Given this list of marker genes Tmt1b, Tpmt, Tmt1a3, Bhmt1b, Inmt, Kmt2a, Tmt1a2, Mgmt, Bhmt, Tmt1a, Mtr, Dnmt3a, Bhmt2, here is a description of the gene set: Catalysis of the transfer of a methyl group to the sulfur atom of an acceptor molecule. Mouse Gene Set: GOMF_S_METHYLTRANSFERASE_ACTIVITY studied in species Mus musculus